The following is a description of a gene set: Genes up-regulated in T cell 3d vs 0d in adults after exposure to 2011-2012 trivalent inactivated vaccine (A/California/7/09 (H1N1), A/Perth /16/2009 (H3N2), B/Brisbane/60/2008), time point 3D. Comment: Up-regulated DE RNA transcripts (up >= 1.5x) shared between both TIV-vaccinated donors Systems biology is an approach to comprehensively study complex interactions within a biological system. Most published systems vaccinology studies have utilized whole blood or peripheral blood mononuclear cells (PBMC) to monitor the immune response after vaccination. Because human blood is comprised of multiple hematopoietic cell types, the potential for masking responses of under-represented cell populations is increased when analyzing whole blood or PBMC. To investigate the contribution of individual cell types to the immune response after vaccination, we established a rapid and efficient method to purify human T and B cells, natural killer (NK) cells, myeloid dendritic cells (mDC), monocytes, and neutrophils from fresh venous blood. Purified cells were fractionated and processed in a single day. RNA-Seq and quantitative shotgun proteomics were performed to determine expression profiles for each cell type prior to and after inactivated seasonal influenza vaccination. Our results show that transcriptomic and proteomic profiles generated from purified immune cells differ significantly from PBMC. Differential expression analysis for each immune cell type also shows unique transcriptomic and proteomic expression profiles as well as changing biological networks at early time points after vaccination. This cell type-specific information provides a more comprehensive approach to monitor vaccine responses. Human Gene Set: HOEK_T_CELL_2011_2012_TIV_ADULT_3DY_UP studied in species Homo sapiens from publication Hoek KL, Samir P, Howard LM, Niu X, Prasad N, Galassie A, Liu Q, Allos TM, Floyd KA, Guo Y, Shyr Y, Levy SE, Joyce S, Edwards KM, Link AJ (PMID 25706537), and this is the list of marker genes: CDCA8, HBB, EFNA1, TCEAL9, RN7SK, LINC00544, BRWD1-AS1, INAFM2, PIK3CD-AS2, TOP2A, NRGN, ZNG1E, LINC02802, CCNB2, UBE2E2, RRM2, LINC01063